Given this list of marker genes AKR1A1, PDXP, AGXT, AGXT2 (alanine--glyoxylate aminotransferase 2), PNKD, HAGH, ADH5, ESD, HOGA1, ADH4, ALDH2, ALDH3B1, PARK7, GATD1, here is a description of the gene set: Human Gene Set: GOBP_ALDEHYDE_CATABOLIC_PROCESS studied in species Homo sapiens The chemical reactions and pathways resulting in the breakdown of aldehydes, any organic compound with the formula R-CH=O.